Given this list of marker genes ntnha, SV2C, VAMP1, ha70, botG, ha17, botA, SYT2, botB, SV2A, botD, botE, STX1B, tetX, VAMP2, botF, SYT1, STX1A (NCBI Gene Id 6804), HA-33, SV2B, SNAP25, here is a description of the gene set: Reactome Pathway: Neurotoxicity of clostridium toxins Clostridial neurotoxins, when taken up by human neurons, block synaptic transmission by cleaving proteins required for the fusion of synaptic vesicles with the plasma membrane. They are remarkably efficient so that very small doses cause paralysis of an affected person. All characterized clostridial neurotoxins are synthesized as products of chromosomal, plasmid or prophage-borne bacterial genes. The nascent toxin may be cleaved into light (LC) and heavy (HC) chain moieties that remain attached by noncovalent interactions and a disulfide bond.<p>Strains of Clostridium botulinum produce seven serologically distinct toxins, BoNT/A, B, C, D, E, F, and G. An eighth toxin, BoNT/H has recently been identified (Barash & Arnon 2014) but its molecular properties have not yet been described. Human poisoning most commonly result from ingestion of toxin contaminated food. More rarely, it is due to wound infection or clostridial colonization of the gut of an infant whose own gut flora have not yet developed or of an older individual whose flora have been suppressed. While all seven characterized toxins can cleave human target proteins, three, BoNT/A, B, and E, are most commonly associated with human disease. BoNT/F is also able to cause human botulism.<p>Once ingested, the botulinum toxin must be taken up from the gut lumen into the circulation, a process mediated by four accessory proteins. These proteins form a complex that mediates transcytosis of the toxin molecule across the gut epithelium, allowing its entry into the circulation. The accessory proteins produced by different C. botulinum strains differ in their affinities for polarized epithelia of different species (e.g., human versus canine), and may thus be a key factor in human susceptibility to the toxins of strains A, B, and E and resistance to the others.<p>Clostridium tetani produces TeNT toxin. Human poisoning is the result of toxin secretion by bacteria growing in an infected wound and the toxin is released directly into the circulation.<p>Circulating clostridial toxins are taken up by neurons at neuromuscular junctions. They bind to specific gangliosides (BoNT/C, TeNT) or to both gangliosides and synaptic vesicle proteins (BoNT/A, B, D G) exposed on the neuronal plasma membrane during vesicle exocytosis. All seven characterized forms of BoNT are thought to be taken up into synaptic vesicles as these re-form at the neuromuscular junction. These vesicles remain close to the site of uptake and are rapidly re-loaded with neurotransmitter and acidified. TeNT, in contrast, is taken up into clathrin coated vesicles that reach the neuron cell body by retrograde transport and then possibly other neurons before undergoing acidification. Vesicle acidification causes a conformational change in the toxin, allowing its HC part to function as a channel through which its LC part is extruded into the neuronal cytosol. The HC - LC disulfide bond is cleaved and the cytosolic LC functions as a zinc metalloprotease to cleave specific bonds in proteins on the cytosolic faces of synaptic vesicles and plasma membranes that normally mediate exocytosis. species: Homo sapiens part of: Uptake and actions of bacterial toxins